The following is a description of a gene set: studied in species Mus musculus Mouse Gene Set: GOBP_NEURAL_CREST_FORMATION The formation of the specialized region of ectoderm between the neural ectoderm (neural plate) and non-neural ectoderm. The neural crest gives rise to the neural crest cells that migrate away from this region as neural tube formation proceeds., and this is the list of marker genes: Kbtbd8, Ednra, Gsc, Lrp6, Sfrp1, Bmpr1a, Sox9, Chrd (chordin), Polr1b, Nolc1, Pef1, Klhl12, Fuz, Tcof1, Pdcd6, Edn1